The following is a description of a gene set: Reactome Pathway: RNA Polymerase II Transcription Pre-Initiation And Promoter Opening electronically inferred by orthology from the curated human pathway studied in species Mus musculus This event has been computationally inferred from an event that has been demonstrated in another species.<p>The inference is based on the homology mapping from PANTHER. Briefly, reactions for which all involved PhysicalEntities (in input, output and catalyst) have a mapped orthologue/paralogue (for complexes at least 75% of components must have a mapping) are inferred to the other species. part of: RNA Polymerase II Transcription, and this is the list of marker genes: Taf7l, Gtf2f2, Gtf2e1, Taf1, Taf11, Polr2l, Taf10, Taf8, Polr2b (polymerase (RNA) II (DNA directed) polypeptide B), Gtf2a1, Polr2c, Polr2i, Taf6, Ercc2, Polr2k, Gtf2b, Taf15, Tbp, Polr2a, Polr2e, Gtf2h4, Taf4b, Ccnh, Taf13, Gtf2h2, Gtf2e2, Ercc3, Taf9b, Polr2f, Gtf2f1, Taf12, Taf5, Taf7